Given this list of marker genes Cd209a, Btn2a2, Xdh, Btn1a1, Ppl, Btnl9, here is a description of the gene set: species: Mus musculus Reactome Pathway: Butyrophilin (BTN) family interactions part of: Adaptive Immune System This event has been computationally inferred from an event that has been demonstrated in another species.<p>The inference is based on the homology mapping from PANTHER. Briefly, reactions for which all involved PhysicalEntities (in input, output and catalyst) have a mapped orthologue/paralogue (for complexes at least 75% of components must have a mapping) are inferred to the other species. electronically inferred by orthology from the curated human pathway